The following is a description of a gene set: Human Gene Set: GOBP_PRIMITIVE_STREAK_FORMATION species: Homo sapiens The developmental process pertaining to the initial formation of the primitive streak from unspecified parts. The primitive streak is a ridge of cells running along the midline of the embryo where the mesoderm ingresses. It defines the anterior-posterior axis., and this is the list of marker genes: GDF3, ETS2, PRICKLE1, LHX1, TBXT, ZIC3, OTX2, NODAL, WNT5A, FOXA2, SRF